The following is a description of a gene set: Poor coordination studied in species Homo sapiens Human Gene Set: HP_POOR_COORDINATION, and this is the list of marker genes: NIPA1, NIPA2, LZTFL1, SLC25A15, EP300, APC2, TINF2, ELN (elastin), HUWE1, ERCC4, SLC6A8, TANGO2, ATP9A, NSD1, KCND3, ARL6, SIM1, TCF20, EED, AFF2, CDC42BPB, TRANK1, TXN2, HSD17B10, RNF168, CARS1, YWHAG, CREBBP, PANK2, CCDC28B, PDE2A, MTR, TUBG1, MLXIPL, SYNGAP1 (synaptic Ras GTPase activating protein 1), BBS1, NAA20, KCNA1, TBC1D23